Given this list of marker genes SIRT1, ABRAXAS1, ZWILCH, RCC2, MIS12, SKA2, BOD1, ZNF207, CDCA8, TEX14, CENPE, INCENP, KAT5, SKA3 (spindle and kinetochore associated complex subunit 3), CDT1, CDK1, BIRC5, CCNB1, SPAG5, KIF2C, NSL1, PMF1, RAB24, ZW10, NEK2, AURKB, RACGAP1, SPC25, CENPC, KAT2B, SGO1, APC, CDC42, NUF2, MAD1L1, KNSTRN, RMDN1, DSN1 (NCBI Gene Id 79980), EML4, SKA1, NDC80, SEH1L, SPC24, SIRT2, AURKC, KNL1, CHAMP1, MAPRE1 (NCBI Gene Id 22919), ECT2, BECN1, ABRAXAS2, RB1, KNTC1, HNRNPU, BUB3, here is a description of the gene set: Human Gene Set: GOBP_ATTACHMENT_OF_SPINDLE_MICROTUBULES_TO_KINETOCHORE The process in which spindle microtubules become physically associated with the proteins making up the kinetochore complex. species: Homo sapiens